The following is a description of a gene set: The branched-chain alpha ketoacid dehydrogenase complex (BCKDH) catalyzes the oxidative decarboxylation of branched-chain keto acids in the mitochondrial matrix as the second step in the degradation of branched-chain amino acids (BCAAs) leucine, valine and isoleucine, providing acetyl CoA and succinyl CoA intermediates for the Krebs Cycle. <br>BCKDH is a multi-enzyme complex consisting of three sub-complexes, the E2 transacylase, the E1 decarboxylase and the E3 dehydrogenase. The core of BCKDH is the E2 transacylase domain, made up of 24 copies of Dihydrolipoamide Branched-chain Transacylase (DBT) arranged in octahedral symmetry. Surrounding the E2 core are 12 copies of the E1 decarboxylase tetramer (each of which consists of a dimer of BCKDHA and a dimer of BCKDHB) and six copies of the E3 dehydrogenase (each consisting of a dimer of Dihydrolipoyl Dehydrogenase (DLD)). The E3 subcomplex is not specific to BCKDH but is also a component of the pyruvate dehydrogenase complex (PDC) and the alpha-ketoglutarate dehydrogenase complex (alpha-KGDC). <br>In addition to the E1, E2 and E3 components, the BCKDH complex also depends on other cofactors- lipoamide for the function of the E2 transacylase, thiamine diphosphate and potassium for the function of the E1 decarboxylase and FAD and NAD+ for the function of the E3 dehydrogenase. <br>The activity of BCKDH is regulated by the association of BCKD kinase (BCKDK) and protein phosphatase 1K (PPM1K) with the macromolecular complex. Phosphorylation of BCKDHB S342 by BCKDK inhibits the catalytic activity of BCKDH, while PPM1K-mediated dephosphorylation activates it. BCKDK is itself negatively regulated by thiamine. <br>Structures for each of the subcomplexes of human BCKDH have been solved, and the complex has a total molecular mass on the order of 4 million Da. <br>Loss-of-function mutations in the BCKDHA, BCKDHB and DBT genes disrupt the stability and the activity of the BCKDH complex, causing an accumulation of branched-chain keto-acids that causes the characteristic odor associated with Maple Syrup Urine disease (MSUD), an inborn error of metabolism with a prevalence of 1:185,000 live births. MSUD is an autosomal recessive disorder and in its classic neonatal form is characterized by a maple syrup odor to the urine, poor feeding, mental and physical retardation, lethargy, seizures, coma and death. Classic MSUD, like the intermediate, intermittent and thiamine-responsive forms described below, may arise as a result of mutations in any of BCKDHA, BCKDHB or DBT. Classic MSUD is characterized by the lowest (~0-3%) residual enzymatic activity of all the forms, and presents clinically during the neonatal period. An intermediate form (residual activity ~3-30%) manifests clinically many months after birth with signs of mental retardation and developmental delay. Patients with the intermittent form of MSUD have normal levels of BCAA and BCKA and normal development and physiology while healthy, but are triggered into manifesting symptoms of MSUD when stressed by, for instance, infection. The existence of a thiamine-responsive form of MSUD, in which symptoms are alleviated by dietary thiamine, is somewhat controversial, but may reflect the inhibitory effect of thiamine on BCKDK, relieving inhibition of BCKDH activity. Mandatory newborn screening programs include testing for MSUD, allowing for early intervention that is especially critical in cases of classic MSUD <br>Mutations in DLD, the E3 subunit shared with PDH and alpha-KGDH, affect the enzymatic activity of all three complexes and are responsible for a more severe disorder called dihydrolipoamide dehydrogenase deficiency (DLDD). DLLD generally results in death in infancy due to lactic acidosis. studied in species Homo sapiens part of: Diseases of branched-chain amino acid catabolism Reactome Pathway: Maple Syrup Urine Disease, and this is the list of marker genes: PPM1K, DLD, DBT, BCKDHB, BCKDHA